Given this list of marker genes STAT3, STAT1, IL2RG, JAK3, JAK1, STAT5B, STAT5A, IL9R, IL9, here is a description of the gene set: part of: Interleukin-2 family signaling Reactome Pathway: Interleukin-9 signaling studied in species Homo sapiens Interleukin 9 (IL9) binds interleukin 9 receptor a chain (IL9R) and the interleukin 2 receptor common gamma chain (IL2RG) to initiate IL9 signaling downstream cascade. IL9R colocalize with Interleukin 2 receptor α chain and MHC molecules in lipid rafts of human T lymphoma cells. IL2RG is essential for IL9 dependent growth signal transduction. IL9R (glycoprotein of 64 kDa) has saturable and specific binding sites with a Kd of 100 pM. The activated IL9R complex recruits tyrosine kinase proteins from the Janus kinase (JAK) family: JAK1 (JAK1) and JAK3 (JAK3) for subsequent activation of the Signal transducer and activator of transcription (STAT) factors STAT1, STAT3 and STAT5. The activated STATs form STAT5 dimers and STAT1:STAT3 heterodimers (Neurath & Finotto 2016, Li & Rostami 2010).